The following is a description of a gene set: Human Gene Set: ACOSTA_PROLIFERATION_INDEPENDENT_MYC_TARGETS_UP Inhibition of differentiation has been proposed as an important mechanism for Myc-induced tumorigenesis, but the mechanisms involved are unclear. We have established a genetically defined differentiation model in human leukemia K562 cells by conditional expression of the cyclin-dependent kinase (Cdk) inhibitor p27 (inducible by Zn(2+)) and Myc (activatable by 4-hydroxy-tamoxifen). Induction of p27 resulted in erythroid differentiation, accompanied by Cdk inhibition and G(1) arrest. Interestingly, activation of Myc inhibited p27-mediated erythroid differentiation without affecting p27-mediated proliferation arrest. Microarray-based gene expression indicated that, in the presence of p27, Myc blocked the upregulation of several erythroid-cell-specific genes, including NFE2, JUNB, and GATA1 (transcription factors with a pivotal role in erythropoiesis). Moreover, Myc also blocked the upregulation of Mad1, a transcriptional antagonist of Myc that is able to induce erythroid differentiation. Cotransfection experiments demonstrated that Myc-mediated inhibition of differentiation is partly dependent on the repression of Mad1 and GATA1. In conclusion, this model demonstrates that Myc-mediated inhibition of differentiation depends on the regulation of a specific gene program, whereas it is independent of p27-mediated cell cycle arrest. Our results support the hypothesis that differentiation inhibition is an important Myc tumorigenic mechanism that is independent of cell proliferation. from publication Acosta JC, Ferrándiz N, Bretones G, Torrano V, Blanco R, Richard C, O'Connell B, Sedivy J, Delgado MD, León J (PMID 18838534) studied in species Homo sapiens Genes up-regulated in K562 cells (lymphoblast) by MYC in the presence of CKN1B., and this is the list of marker genes: CD320, GLS, ENSG00000291006, GCSH, SLC39A4, UCK2, CSE1L, PRPF19, NQO1, SKP2, FBXO41, URI1, LPL, ZNF395, PEX5, GCDH, MATK, PTK7, CCNE1, HILPDA, SLC27A2, DUSP9, EIF3J (eukaryotic translation initiation factor 3 subunit J), PSMG1, NUP210, ZNF460, PWP1, SORD, LAS1L, STUB1, AATF, REPIN1, LYPLA1, CLUH, BLMH, EIF4A3, PEBP1, SLC39A6, OPN3, TSPO, RRP1B, JAG2, GNPDA1, CUTC, DDX28, SLC19A2, SLC29A1, SPG21, NOLC1, GLOD4, MTMR4, NUP214 (NCBI Gene Id 9680), RGS16, EXPH5, SLC17A7 (solute carrier family 17 member 7), TRIAP1, RIOX2, NRTN, EMC1, MRPL4, XPO6, TMEM161A, NR1D2, CRYBG2 (crystallin beta-gamma domain containing 2), PARP1, RCHY1, ODC1, DHCR7, RAB3A, VPS13C, GLB1L2, CTPS1, MAST2, STEAP1, HDHD5, PDCD11, LEPR, WDR74, MTRR, SLC5A3, MPZL1, OXCT1, KIAA0930, RGS14